The following is a description of a gene set: Mouse Gene Set: GOBP_HAIR_FOLLICLE_PLACODE_FORMATION The developmental process in which a hair placode forms. An hair follicle placode is a thickening of the ectoderm that will give rise to the hair follicle bud. studied in species Mus musculus, and this is the list of marker genes: Hdac1, Dkk4, Eda, Hdac2, Gnas, Ctnnb1